Given this list of marker genes COL2A1, COMP, TRPV4, EZH2, COL11A2, here is a description of the gene set: Flared femoral metaphysis studied in species Homo sapiens Human Gene Set: HP_FLARED_FEMORAL_METAPHYSIS